Given this list of marker genes Gdf5, Sema3c, Hand2, Gja1 (gap junction protein, alpha 1), Pcsk5, Wdpcp, Idua (NCBI Gene Id 269679), Tgfb2, Rdh10, Hoxa10, Fbn2, Zfp219, Fgf4, Nog, Hoxc11, Fras1, Bpnt2, Aldh1a2, Prrx2, Cibar1 (CBY1 interacting BAR domain containing 1), Msx2, Cacna1c, Plxna2, Hoxd12, Cplane1 (NCBI Gene Id 73692), Pitx1, Rspo2, Map3k20, Hotair, Dkk1, Evx2, Hnf1a, Shh, Fzd6 (NCBI Gene Id 14368), Ift140, Atrx, Sox9, Tmem231 (transmembrane protein 231), Reck, Sall1 (NCBI Gene Id 58198), Lmx1b, Tulp3, Fgf10, Tbx3, Runx2, Enpp1, Dlx6 (distal-less homeobox 6), Med1, Rarg, Mbnl1, Notch2, Flvcr1, Tbx4, Shox2, Frem2, Smarca4, Gna12, Ptch1, Gas1, Wnt9a, Alx1, Npr2, Dync2h1, Tfap2b, Prrx1, Tfap2a, Sp9 (NCBI Gene Id 381373), Errfi1, Nfia, Hoxd10, Col2a1, Iqce, Osr2, Sik3, Sfrp2, Sall3, Pcnt, Hdac1, Fgfr2, Gpc3, Pitx2, Msx1 (NCBI Gene Id 269644), Ctnnb1, Prickle1, Ift52, Col6a1, Fgf8, Bmp4, Gnas, Ttbk2 (NCBI Gene Id 98929), Rpgrip1l, Gnaq, Ext1, Ihh, Mecom, Osr1, Ift122, Dicer1, Fmn1, Dlx5, Bcl2l11, Cyp26b1, Psen1, Ark2c, Pbx2, Psen2, Atp7a, Crabp2 (NCBI Gene Id 99759), B9d1, Lef1, En1, Bmpr1a, Lmbr1, Zbtb16, Tmem107, Hottip, Bmp7, Hoxa9, Traf3ip1, Hoxc10 (NCBI Gene Id 209448), Pbx1 (pre B cell leukemia homeobox 1), Grem1, Hoxd13, Tbc1d32, Wnt5a, Vps54, Gli3, Bax, Tbx5, Fbxw4, Notch1, Alx4, Ece1, Hoxd11, Sall4, Tbx2 (NCBI Gene Id 21385), Alx3, Hoxd9, Hoxa13, Zic3, Intu, Wnt3, Rab23, Rarb, Smad4, Mosmo, Mir23a, Fuz, Lnpk (lunapark, ER junction formation factor), Fgfr1, Large1, Asph, Lrp4, Chst11, Acd, C2cd3, Col3a1, Lrp6, Mks1, Mycn, Gli2, Hoxa11, Megf8, Gja5, Hdac2, Trp63, Ift88, Aff3, Sp8, Ski, Wnt7a, Wdr19, Fgf9, Grhl2, Chd7, Twist1, Ror2, Bak1, Nipbl, Lrp5, Pkdcc, Sulf1, here is a description of the gene set: The process in which the anatomical structures of appendages are generated and organized. An appendage is an organ or part that is attached to the trunk of an organism, such as a limb or a branch. Mouse Gene Set: GOBP_APPENDAGE_MORPHOGENESIS studied in species Mus musculus